Given this list of marker genes MAPK6P5, RNU7-84P, NDUFB9P3, H2AZP7, TMCC1P1, ZFPM2-AS1, EEF1A1P37, NUDCD1, RPL30P16, ENSG00000253796, RPS17P14, ENSG00000304557, ABRA, TMEM74, MTCO1P47, MIR2053, NRBF2P4, SYBU, TRHR (thyrotropin releasing hormone receptor), OXR1, SERPINA15P, RPL12P24, SLC16A14P1, LINC01609, EBAG9, TRPS1-AS1, LINC01608 (long intergenic non-protein coding RNA 1608), CARS1P2, PGAM1P13, OXR1-AS1, ENSG00000287826, ENY2, RSPO2, RNA5SP275, ANGPT1, RPSAP48, RNA5SP276, EMC2, KCNV1, HMGB1P46, LINC03084, SYBU-AS1, TRPS1, RNU4-37P, AURKBP1, LINC02237, EIF3E, ENSG00000287819, TAGLN2P1, CSMD3, LINC00536, PKHD1L1, here is a description of the gene set: studied in species Homo sapiens Human Gene Set: chr8q23